The following is a description of a gene set: Genes predicted to be targets of miRBase v22 microRNA hsa-miR-1301-5p in miRDB v6.0 with MirTarget v4 prediction scores > 80 (high confidence targets). species: Homo sapiens from publication Chen Y, Wang X (PMID 31504780) Human Gene Set: MIR1301_5P, and this is the list of marker genes: INSM2, WNT2, MAN1A2, MIER3, NUDT7, TRABD2B, TAOK2, WNK1, ADD3, SLC35A1, CPEB2, LHCGR, TSPAN7, RGS8, ERI1, FAM98A, ZRANB1 (zinc finger RANBP2-type containing 1), RABEP1, HMGN3, SNAP25, TEP1 (telomerase associated protein 1), ARIH1, MYLK3, LRAT, KCNMB2, NCK1, SCD5, THSD7A, ISLR, ZFHX2, RNF166, XRN1, TRIM8, EIF4E2, CAMSAP2, SLC6A1, TMEM33, SNX18, HTR5A, MACIR, ZBTB34, N4BP2L1, MAP2, HOXB13, OOSP2, RNF10, B3GNT2, ANKRD42, NCSTN, ADAM12, GPD2, URI1